Given this list of marker genes SENP2, SENP1, SUMO3, SENP5, SUMO2, SUMO1, here is a description of the gene set: Human Gene Set: REACTOME_SUMO_IS_PROTEOLYTICALLY_PROCESSED species: Homo sapiens SUMO is proteolytically processed